Given this list of marker genes TMEM256, TP53, C14orf119 (chromosome 14 open reading frame 119), DPF1, BCL7A, AKT2, MTF2, RLIM, RTN2 (reticulon 2), PIM1, EIF4G1 (eukaryotic translation initiation factor 4 gamma 1), ACSBG2, PHF12, PRKCG, PTMS, LRP1, HR, HOXA10, NOTCH2, FAM131C, VGF, TAOK2, MTHFR, PRKAG1, LRP2, RSRC2, HOMEZ, DCN, CLUH, ARHGEF17, SMARCA2, EPC1, MAP1A, ITPR1, EEF1G, KLK12, ACAN, PKIA, DLX1, NR4A3, AAMP, RALB, PROCR, EEF1A1, HOXC4, NEDD4L, NRGN, HIF1A, OTX2, FBXO36, HEBP2, KANSL1L, IGF2BP1, KPNB1, KIRREL2, MARK2, KRT13, WRAP53, KLF13 (NCBI Gene Id 51621), NEUROD2, CACNG2, PRRX1, UBE2Z, NMT1, STAU1, ASPHD1, PTGR3, UBE2B, SDC1, PPP1CB, PHACTR3, MED12, RBM47, APOA2, TRIR, YBX3, EFNB3, NTF4, HPCAL4, ZBTB7A, CCDC81, C1orf43, VPS35, RTN4RL2, AP1G1, NUFIP2, RAB11B, INCA1, MEF2D, ROCK1, ZFYVE1, KIF3C, PBX1, ZMYM2, SYVN1 (NCBI Gene Id 84447), INPP4A, KCNS3, DCHS1, CDK12, ZNF521, IGFBP5, RFTN2, CHL1, RAB6A, DCTN2, SLC2A4, ACVR1B, RTN3, ABI3, ADAMTS4 (ADAM metallopeptidase with thrombospondin type 1 motif 4), MINK1, CLC, CTDSPL2, UBFD1 (ubiquitin family domain containing 1), NPAS4, CASKIN2, ORC6, DMD, EMX2, NOL4, FOXA2, MRTFA, LASP1, TPPP3, ATP6V0C, RSPRY1, TSEN54, NTN3, ITGA6, PDGFB, LIN28A, GNB4, S100A14, DDX17, NOTCH2NLA, RAB6B, PIP4K2B, NFIX, HNRNPH3, TOR1AIP2, ADAMTS9, GNGT2 (NCBI Gene Id 2793), GRK5, CDK17, ZSWIM3, TRIM46, KNTC1, AP4S1, NEGR1, ARHGAP5, ZNF436-AS1, PABPN1, SIK2 (NCBI Gene Id 23235), HOXC6, MNT, KRTCAP2, PRSS36, GNAO1, MYH10, STRN3, HOXB9, FZD4, CACNA1G, OCEL1, SEPTIN4, NR1H3, HNRNPR, ZNF436, YWHAQ (tyrosine 3-monooxygenase/tryptophan 5-monooxygenase activation protein theta), ARPC2, ZNF579, CACNA1D, PSME3IP1, EMID1, ATF3, ARL4C, ZNF385A, ADRA1D, MAGED2, THBS3, RCOR2, CIART (NCBI Gene Id 148523), JPH4, CBX6, ACIN1, RPRD2, FGF11, WBP1L, ARHGEF12, PYGO1, DCTN1, KAT5, ACVRL1, LINC00303, FOXS1, NXPH3, MTX1, KCNN3 (NCBI Gene Id 95947), RALBP1, PICALM, USF2, CHRM1, RFX1, NCAM1, IVD, HOXB8, SYT6, MPC2, ACOT8, DTNA, KCNJ14, HOXB6, KIF1C, PNKD, FBRS, NCDN, SALL1, CLCN6, GDPD2, ARF3, CHP1, MMP1, AHR, SUPT16H, PSD, ACR, NDUFS2 (NCBI Gene Id 4720), BCL11A, YPEL4, MYBPH (NCBI Gene Id 4608), ROGDI, CLMP, HHATL, EXD1, NKX2-1, DCAKD, MBD6, POU2F1, LRFN5, TNNC1, SIX4, ARHGAP44, GNAI2, GABPB2, BRSK2, MGAT3, here is a description of the gene set: Human Gene Set: CACBINDINGPROTEIN_Q6 studied in species Homo sapiens Genes having at least one occurrence of the motif GRGGSTGGG in the regions spanning 4 kb centered on their transcription starting sites. This matches the transcription factor binding site V$CACBINDINGPROTEIN_Q6 (v7.4 TRANSFAC).